The following is a description of a gene set: Any process that stops, prevents or reduces the frequency, rate or extent of microRNA processing. Mouse Gene Set: GOBP_NEGATIVE_REGULATION_OF_MIRNA_PROCESSING species: Mus musculus, and this is the list of marker genes: Mecp2, Zc3h10, Il6, Lin28b, Zmpste24, Lin28a, Bcdin3d, Hnf1a, Trp53, Mir361, Stat3